Given this list of marker genes TCN2, here is a description of the gene set: studied in species Homo sapiens part of: Defects in cobalamin (B12) metabolism Reactome Pathway: Defective TCN2 causes TCN2 deficiency Defective transcobalamin II (produced by the TCN2 gene) results in TCN2 deficiency (MIM:275350), an autosomal recessive disorder with early-onset in infancy characterized by failure to thrive, megaloblastic anemia, and pancytopenia. If left untreated, the disorder can result in mental retardation and neurologic abnormalities.